Given this list of marker genes Adgrb1, Nfatc2, Cxcl9, Myod1, Mapk14, Cd53, Flt3l, Capn2, Flot1, Il4ra, Ripor2, Ehd2, Gdf15, Ccl8, Il4, Ehd1, Tnfsf14, Scgb3a1 (NCBI Gene Id 68662), Cxcl12 (NCBI Gene Id 20315), here is a description of the gene set: Mouse Gene Set: GOBP_POSITIVE_REGULATION_OF_MYOBLAST_FUSION studied in species Mus musculus Any process that activates or increases the frequency, rate or extent of myoblast fusion.